The following is a description of a gene set: species: Homo sapiens Human Gene Set: HP_RECURRENT_PAROXYSMAL_HEADACHE Recurrent paroxysmal headache Repeated episodes of headache with rapid onset, reaching a peak within minutes and of short duration (less than one hour) with pain that is throbbing, pulsating, or bursting in quality., and this is the list of marker genes: SDHD, TMEM127, MT-TS2, MT-TL1, VHL, MT-ND1, MT-CO3, NF1 (NCBI Gene Id 646021), SLC25A11, DLST, MT-TF (NCBI Gene Id 4558), MT-TW, MT-TH, MAX, MT-ND6, MT-ND4, EPAS1 (endothelial PAS domain protein 1), MT-CO2, SDHC (NCBI Gene Id 6391), MT-ND5 (NCBI Gene Id 4540), MDH2, SDHB, MT-CO1, MT-TQ, DKK1, DNMT3A, RET, FH, SDHA, SDHAF2 (NCBI Gene Id 54949), KIF1B